Given this list of marker genes ASCC1, TTR, GJB1, LAMA2, GBE1, HNRNPA1, MTRFR, HSPB1, TYROBP, RNF220, UBQLN2, DHX9, POLG2, KIF1B, SLC25A46, MME, SCO2, TK2 (thymidine kinase 2), COG8, UBTF, ATXN3, GLE1, FXN, GBF1, SLC12A6, VPS13D, NEFL, SAMD9L, MT-TW, KCNK9, DDHD1, MPZ, KIF5A, TUBB3, ABCA1, MT-TE, TRIP4, TRAPPC11, MORC2, MPV17, TXN2, ATP13A2, TDP1, LIG3, AMPD2, MT-TL1, HEXB, VPS41, PRPS1, WDR48, SPG7, XRCC4, KLHL9, LRSAM1, HNRNPA2B1, C19orf12, GBA2, SERPING1, ERCC6, SH3TC2, KLC2 (NCBI Gene Id 64837), RAB7A, RFC1, MARS1, CAPRIN1, ATL3, ADPRS, SLC25A4, AAAS, CYP27A1 (cytochrome P450 family 27 subfamily A member 1), KCNJ11, DHX16, KRAS, MT-CO3, UCHL1, IFRD1, FIG4, ATAD3A, TRIM2, KIF1A, COA7, ABCC8, TRPV4, BIN1, PLOD1, AIFM1, MT-CO1, MT-TS2, ACOX1, KCNJ10, GNB4, HMBS, TBCD, DARS2, BAG3, REEP1, MT-ATP6, MT-ND5, ATP1A3, FLRT1, KPNA3, VWA1, FBLN5, PMP22, SYNE1, IGHMBP2, MFN2, TWNK, ALDH18A1, CCT5, VPS13A, MT-TQ, ERBB2, PRICKLE1, SLC25A19, DCAF8, MT-TF, NEUROG1, DNM2, MT-ND6, NEFH, NAGA, HINT1, MT-ND1, PSAP (NCBI Gene Id 83009), STAT3, XK, PNPLA6, EXOSC8, IBA57, AFG3L2, KARS1, ELOVL5, SPTLC1, SPTBN4, SEPTIN9, ELOVL4, ABCD1, HK1, FGF14, ATP11A, NGLY1, COX20, MTMR14, TBCE, POLG, COASY, PLD3, RYR1, CAPN1, MOCS1, CTSD, EXOSC9, FLVCR1, TFG, VRK1, HSPB8, PEX10, RTN2, PDX1, CTDP1, MT-TH (NCBI Gene Id 4564), PLEKHG4, DYNC1H1, PIK3R5, SETX, JPH1, MCM3AP, DGUOK, GCK, WFS1, RNU4-2, GMPPA, MYF6 (NCBI Gene Id 4618), RNF170, WARS1, MICU1, RRM2B, NDRG1, VCP, OPA1, YARS1, MOCS2, MT-CO2, PLXNA1, SPTAN1, PIEZO2, SPTLC2, SHMT2, HARS1, SLC25A21 (solute carrier family 25 member 21), ZFYVE26, PIGB, LMNA, RETREG1, MT-ND4, GNB2, BRAF, GAN, AARS1, ERCC8, ATL1, AGTPBP1, GDAP1, SURF1, SPG11, NEMF, TYMP, GJC2, INS, PTRHD1 (peptidyl-tRNA hydrolase domain containing 1), INF2, EXOSC3, APTX, CYP2U1, TTC19, PLA2G6 (NCBI Gene Id 8398), here is a description of the gene set: species: Homo sapiens Human Gene Set: HP_PERIPHERAL_AXONAL_DEGENERATION Progressive deterioration of peripheral axons. Peripheral axonal degeneration